Given this list of marker genes GNB1L, CHCHD4, BNIP3, CELA1, CA13, PRRX2, RANGRF, CLDN2, RGS11, FGD1, GLIPR1, LAMB1 (NCBI Gene Id 3912), CNNM3, TLX1, RASA2, EGF, TBX20, MPG, NFX1, HDGF, HDAC6, HDGFL1, CHCHD5, CEACAM1, CA5A, CTNNBIP1, EFNA4, CDH3, BCL2L14, BRCA1, TCP10L, EMB, COL26A1, CIAPIN1, here is a description of the gene set: Genes up-regulated in the mouse lung cancer model and which reverted to normal levels upon treatment with bexarotene. species: Mus musculus Human Gene Set: WANG_RESPONSE_TO_BEXAROTENE_UP Bexarotene (Targretin), is a synthetic high-affinity RXR receptor agonist with limited affinity for RAR receptors. Bexarotene has shown efficacy in a phase I/II trial of non-small-cell lung cancers. However, the chemopreventive efficacy of bexarotene has not been determined in mouse lung cancer models. In this study, we have investigated the ability of bexarotene to inhibit lung tumor progression in the mutant A/J mouse models with genetic alterations in p53 or K-ras, two of the most commonly altered genes in human lung tumorigenesis. Mice were administered vinyl carbamate (VC), a carcinogen, by a single intraperitoneal injection (i.p.) at 6 weeks of age. Bexarotene was given by gavage starting at 16 weeks after VC and was continued for 12 weeks. Although all mice developed lung tumors, only 7% of lung tumors were adenocarcinomas in wild-type mice, whereas 22 and 26% of lung tumors were adenocarcinomas in p53 transgenic or K-ras heterozygous deficient mice. Bexarotene inhibited both tumor multiplicity and tumor volume in mice of all three genotypes. Furthermore, bexarotene reduced the progression of adenoma to adenocarcinoma by approximately 50% in both p53(wt/wt)K-ras(ko/wt) and p53(wt/wt)K-ras(wt/wt) mice. Thus, bexarotene appears to be an effective preventive agent against lung tumor growth and progression. from publication Wang Y, Zhang Z, Yao R, Jia D, Wang D, Lubet RA, You M (PMID 16247446)